The following is a description of a gene set: The chemical reactions and pathways resulting in the breakdown of a vitamin, one of a number of unrelated organic substances that occur in many foods in small amounts and that are necessary in trace amounts for the normal metabolic functioning of the body, carried out by individual cells. Human Gene Set: GOBP_VITAMIN_CATABOLIC_PROCESS species: Homo sapiens, and this is the list of marker genes: MTHFS, CYP26A1, CYP26C1, CYP4F2, CYP26B1, CYP24A1, CYP2W1, CYP27B1, PDXP, CYP4F8, CYP4F12, CYP4F3, FGF23, CBR3 (NCBI Gene Id 874), CYP3A4, CYP4F11, PM20D2